The following is a description of a gene set: studied in species Mus musculus Mouse Gene Set: GOBP_N_TERMINAL_PROTEIN_AMINO_ACID_ACETYLATION The acetylation of the N-terminal amino acid of proteins., and this is the list of marker genes: Naa20, Ep300, Aanat, Naa80 (NCBI Gene Id 56441), Naa50, Naa16, Crebbp, Naa12, Naa60, Naa11 (N(alpha)-acetyltransferase 11, NatA catalytic subunit), Naa15, Naa10, Sox4, Kat2b